The following is a description of a gene set: Human Gene Set: GOBP_REGULATION_OF_THYMOCYTE_APOPTOTIC_PROCESS studied in species Homo sapiens Any process that modulates the occurrence or rate of thymocyte death by apoptotic process., and this is the list of marker genes: BMP4, ADAM8, JAK3, TP53, BCL11B, ADA, PTCRA, EFNA1, ZC3H8, HIF1A, RORC, KIFAP3, BBC3 (BCL2 binding component 3), WNT5A, RAG1